Given this list of marker genes BEND4, ZNF708, IQCK, C1QTNF3, APCDD1L, AKR1B10, PIK3CG, OGDHL, HJV, MAP1LC3B, TOX3, CCNDBP1, SLC2A8, ZNF431 (NCBI Gene Id 170959), SLC26A4, KPNA4, SIAH1, PPFIA1, ZNF430, TENT5D, SLC6A15, AKR1B15, LONRF1, ATP5MG, CAVIN2, NDEL1, EFNA5, MAP4K3, AFP, DENND3, ITGB1BP1, PPA2, B4GALT5, CHML, RAB35, LIMD1, MTRF1L, KCNE3, GPC6, AFF3, SNX18, FAM169A, JTB, NEBL (NCBI Gene Id 51739), SPMIP4, GABRA4, CD2AP, SLC6A6, GLI1, POC1B, CDA, GPR63, ZNF215, ADAM12, PUS10, ZNF714, DAW1, JMY, CAMSAP2, IFNW1, ZNF100, ZSWIM5, DCAF12, YLPM1, OPCML, MMUT, NALF1, GLIS1, ITM2B, SPATA12, BBX, TPRKB, NAA30, BBS9 (Bardet-Biedl syndrome 9), GIGYF2, KLF7, COL8A2, SERINC4, MBNL3, SIGMAR1, PALS2 (protein associated with LIN7 2, MAGUK p55 family member), RFC5, LIAS, MEGF11, CCDC88A, PSD3, ATL2, SV2C, PTGR3, SYNPO2, RMND5A, MYH11 (myosin heavy chain 11), GMNC, ATG7, AMMECR1, ZFHX4, ILDR1, PKP2, PEX1, ZNF506, GJA1, GOLGA8J, KLF8, DNAJC25-GNG10, CDK8, ADGRL4, GBP2, TPPP, PRSS35, RPL28, WNT16, MSI2, ZNF677, NR5A2, CUX1, TMEM41B, NIPSNAP2, SOD1, HSPA12A, PARP15, PHC3, TMEM150C, COX11, DCBLD2, SLC35B2, HECW2, TOM1L2, SYK, NLGN1, LRIG2, ARFIP1 (NCBI Gene Id 27236), ZNF681, SOX7, MAGI2 (membrane associated guanylate kinase, WW and PDZ domain containing 2), ZNF257, GFM1, GNG10, MACO1, H2BC21, UTP14C, MAP1LC3B2, DDIT4L, LMO4, ETFA, BEND7, HSPA13, ELOVL4 (ELOVL fatty acid elongase 4), ZNF208, FEM1B, SLC38A1, CYB5B, HERC4, PDE1C, CALD1, ZNF608, SYNDIG1, KLK7, NR3C1, here is a description of the gene set: Human Gene Set: MIR4679 studied in species Homo sapiens Genes predicted to be targets of miRBase v22 microRNA hsa-miR-4679 in miRDB v6.0 with MirTarget v4 prediction scores > 80 (high confidence targets). from publication Chen Y, Wang X (PMID 31504780)